Given this list of marker genes Sf3b1, Vgll3, Pax9, Grpel2, Adam10 (a disintegrin and metallopeptidase domain 10), Igsf10, Plekhf2, Pip4p1, Nbea, Bmal1 (NCBI Gene Id 11865), B3gnt5, Scn9a, Ankrd50, Pum1, Pmepa1, Hltf, Rgs20, Epc2, Smndc1, Phf5a, 2510009E07Rik, Gas6, Wdfy3, Zic1, Zdhhc13, Nck1, Tbp, Mecom, Cyp2j6, Gucy1a2, Ago3, Tnrc6b, Pyurf, Il23a, Magt1 (magnesium transporter 1), Boc, Jag2, Cntln, Fbxo25, Sbno1, Furin, Atg4d, Arih1, Rcan2 (NCBI Gene Id 53901), Ddx59, Lef1, Ano4, Pnn, Map3k12, Cacnb2, Rbbp6, Grip2, Sorbs1, Lmna, Ppp6r3, Zranb3, Arid4b, Lztfl1, Fst, Rgs16, Aifm2, Mtf2, Bbs5, Uso1, Jdp2, Dzip3, Gsk3b, Azin1 (antizyme inhibitor 1), Trps1, Sp9, Aebp2, AI987944, Ift122, Gm4297, Gm5934, Brs3, Fgd4, Stam, Dmxl2, Cyp51, Grm8, Cyth1, Uncx, Il36rn, Lsm1, Edem3, Atrx, Stmn3, Caps2, Dlst, Celf4, Rbm25, Zbtb6, Mcc, Emc3, Hdac8, Mfsd14a, Arap2, Crim1 (NCBI Gene Id 50766), Smad6, Vps29, Arl8a, Zfp935, Atp2a1 (ATPase, Ca++ transporting, cardiac muscle, fast twitch 1), Snx13, Dusp6, Lrp6, Loxhd1, Haus2, Gcnt1, Lonrf3, Clca3b, Olig3, Crh, Tshz1, Zfp688, Gabpb1, Epb41l3, Usp32, Gpc6, Pkp4, Chic1, AW146154, Opn1mw, Brwd3, Pdgfc, Mllt3, Krt6b, Ugt2b37, Fpgt, Pum2, Nexmif (NCBI Gene Id 97590), Garnl3, Dop1b, Bicd1, Lgr4, Rimklb, Rab6a, Prph, Fkbp3, Trafd1, Lin9 (lin-9 DREAM MuvB core complex component), Lrrc58, Cd200r1, Ube2e2, Ankrd12, Kat6a, Dner, Glrb, Rbm3, Ptpn6, Cep170, Kpna4, Fezf2, Tbcel, Capza1 (capping actin protein of muscle Z-line subunit alpha 1), Thoc2, Papolg, Slf2 (SMC5-SMC6 complex localization factor 2), Dok5, Cyyr1, Gpd1l, Ephb4, Pxdn, here is a description of the gene set: from publication Chen Y, Wang X (PMID 31504780) Genes predicted to be targets of miRBase v22 microRNA mmu_miR_7678_5p in miRDB v6.0 with MirTarget v4 prediction scores > 80 (high confidence targets). Mouse Gene Set: MIR_7678_5P studied in species Mus musculus